Given this list of marker genes FRY, TLE3, NCKAP1L, PAQR7 (NCBI Gene Id 255358), DPYSL2, PAN2, SEMA4D, RETREG2, MIR340, CSGALNACT2, ETV3, TMPRSS11GP, SIGIRR, DTWD1, SCPEP1, CCNL2, LRRC8B, LYSMD1, ACSF2, PDPK1, ARID5B, C6orf118, ARL4C, LRRC8A, GTDC1, LIMK2, ERLIN2, BCKDHB, PCMTD2, LRATD2, PMAIP1, RANBP3, TIMM22, SYNJ1, PCCB, B3GALT2, ZFP36L2, FGD6, HSD17B7, ACP3, C5orf63, WDR76, SPPL2B (signal peptide peptidase like 2B), SCARNA13, TPM3, GABRG2, GATA3, WDR83OS, TUBG2, CIPC, H1-0, PDE4D (phosphodiesterase 4D), ACACA, MATN2, CMAHP, UPF1, STIMATE, DCAF8, DFFA, MAPK6 (mitogen-activated protein kinase 6), RBCK1 (RANBP2-type and C3HC4-type zinc finger containing 1), ANKS3, ACAP3, OLFM5P, KIF1C, ZBTB34, PDZD8, TARBP1, CD81, REEP5, EEIG1, SEPTIN9, CNGA1, RAB3D, SMAD5, MCOLN3, JAK1, HELB, CNOT10, RBM22 (NCBI Gene Id 55696), CYRIA, TBC1D10B, ZC3H4, CAPN1, POFUT1, DAPK3, ANGPTL2, CD3G, HNRNPUL1, ALPK1, TBC1D22B, UBR5, FUT8, PABIR2, AOC2, STRIP1, ALDH5A1, STRN4, DENND6A, UBE4A, PMS2, ATP2A3, LTN1, IRF2BPL, AK3, SLC39A9, FKBP15, TMEM107, GPD2, HNRNPL, FOXP4, DYNC2H1, NOL6, PELP1, GNB4, ZFYVE26, FAAH, PPIP5K1, TMEM134, INSIG1, GCLC, IST1, MOGS, SF1, PHYHIP, FAM234A, OTUD5, TGFBR3, SUSD2, NAA60, UBA1, MTMR3, SH3BP5, MTSS1, TAF5, SBF1, WDR37, MAP4K5, DAZAP1, PCNX3, SUN1, RPRD2, CPNE4, DPP7, HDAC4, DNAJC10, L1CAM, DMRTC1B, ALG2, NAT10 (NCBI Gene Id 79715), AKAP11, ZDHHC8, MAPDA, MTG2, SMPD1, STAU2, TET1, TTBK2, ITPKB, SMIM7, CCDC88A, CDCA7, EHMT2, SCG3, OSBPL11, TCEAL8, CASC3, NUB1, LHFPL3, SLC19A2, DEPDC5, EIPR1, GNG10, UBE2O, VIM, SMYD2, ZRANB1, SEMA4F, SQOR, STX2, here is a description of the gene set: from publication Gardam S, Sierro F, Basten A, Mackay F, Brink R (PMID 18313334) Tumor necrosis factor-associated factors 2 and 3 (TRAF2 and TRAF3) were shown to function in a co-operative and non-redundant manner to suppress nuclear factor-κB2 (NF-κB2) activation, gene expression and survival in mature B cells. In the absence of this suppressive activity, B cells developed independently of the obligatory B cell survival factor, BAFF (B cell activating factor of the tumor necrosis factor family). This constitutive, lineage-specific suppression of B cell survival by TRAF2 and TRAF3 determines the requirement for BAFF to sustain B cell development in vivo. We wished to investigate the effect on gene expression in B cells which lacked the negative regulators TRAF2 and TRAF3, and hence had hyperactive NF-kB2 signalling. As Baff-tg mice display a similar phenotype, and have a genetic modification which acts in the same pathway, yet further up, than TRAF2 and TRAF3, we wished to compare and contrast Baff-tg B cells with TRAF2 and TRAF3 deficient B cells. This analysis should identify genes that are important in B cell survival. species: Homo sapiens Human Gene Set: GSE10422_WT_VS_BAFF_TRANSGENIC_LN_BCELL_UP Genes up-regulated in wildtype B cells versus BAFF-transgenic (over-express TNFSF13B) B cells from lymph node.